The following is a description of a gene set: species: Homo sapiens Human Gene Set: HP_PRIMARY_ADRENAL_INSUFFICIENCY Primary adrenal insufficiency Insufficient production of steroid hormones (primarily cortisol) by the adrenal glands as a result of a primary defect in the glands themselves., and this is the list of marker genes: PEX2, HSD17B4, GLI3, CYP11A1, PEX19, PEX14, PEX11B, MRPS7, TCTN3, PEX3, PEX13, PEX10, PEX6, NR0B1 (nuclear receptor subfamily 0 group B member 1), PEX5, ABCD1, AIRE (NCBI Gene Id 326), PEX12, PEX26, KANSL1 (NCBI Gene Id 791085), PEX1, PEX16, CYP17A1